Given this list of marker genes RNF186, DRG1, ZBTB46, PCSK4, SUGP1, SRSF5, SDHD, YIF1A, USP16, TP53, ATP2C1, PCDHB2, LRRC41, ABCC1, STARD10, ANK3, AGFG1, CD44 (NCBI Gene Id 960), NCAM1, LYAR, ACP1, ICOSLG, ELK4, CEBPG, RBP5 (retinol binding protein 5), NPL (N-acetylneuraminate pyruvate lyase), MMUT, NCAPG, POLR1E, BOK, BUD13, NUP155, GLOD4, MAP10, TFCP2, ZNF22, HNRNPC, PRUNE1, PABPC1, MYCN, TUBB1, GOT1, RDX, ATG13, FOSL2, RPS14, HP1BP3, ENOX1, NDUFA7, AGO1, ACTA1, SLC8B1, EDEM2, HMGN1, PRIM1, UTP18, CAB39, ATP5MF, IRF6, SPNS1, PTPN12, IMP3, SEMA7A, NUDT5 (NCBI Gene Id 11164), CLEC1B, MUC5B, MPDU1, PRSS1, STAM, DUSP8, ATP6V1B1, SLC25A22, HCCS, AGPS, SENP3, THNSL1, EIF3K, DNAJC11, FGFR3, SANBR, CSPP1, ZNF207, ERGIC1, PRELID1, TNPO1, XPOT (NCBI Gene Id 11260), IRF7, ZFHX3, PAM16, SETDB2, CD4, UFM1, ILF3, GAMT, MED4, CPZ, COL13A1, here is a description of the gene set: Human Gene Set: MODULE_567 studied in species Homo sapiens Genes in the cancer module 567.